Given this list of marker genes CDC16, BUB1B, SPC25, NUP133 (NCBI Gene Id 55746), CENPM, KIF2A, NUP107, CLIP1, ANAPC2, MIS12, ANAPC5, RANGAP1, ZWILCH, SPDL1, DYNC1H1, KIF2B, CENPA, PPP2R5E, PPP1CC, NDE1, SGO1, ERCC6L, ANAPC10, CENPS, PPP2R5D, AHCTF1, UBE2C, CENPH, SEC13, NUDC, KNTC1, ANAPC4, CENPU, ANAPC15, NDEL1, RPS27, ZWINT, PPP2CB, ZW10, DYNC1I2, KIF2C, CENPN, SKA1, SGO2, KNL1, PPP2R5B, SEH1L, DYNC1LI2, UBE2S, KIF18A, NUF2, BUB3, UBE2D1, ITGB3BP (NCBI Gene Id 23421, integrin subunit beta 3 binding protein), CDC26, CENPT, RCC2, NUP37, RANBP2, TAOK1, XPO1, CLASP1, PPP2R1B, ANAPC16, CDC23, NSL1, ANAPC1, DYNC1I1, CKAP5, PPP2R5C, NUP160, ANAPC7, PPP2CA (protein phosphatase 2 catalytic subunit alpha), CENPQ, CENPK, ANAPC11, PAFAH1B1, NUP43, PMF1, CENPF, NUP85, CENPE, B9D2, CLASP2, MAPRE1, MAD2L1, DYNLL2, PLK1, MAD1L1 (NCBI Gene Id 8379), DSN1, NUP98, NDC80, PPP2R1A, CENPP, PPP2R5A, CENPC, CDC20, CDC27, CENPL, CDCA8, BIRC5, DYNLL1, INCENP, SKA2, UBE2E1, CENPO, DYNC1LI1, CENPI (centromere protein I), AURKB, SPC24, BUB1, here is a description of the gene set: species: Homo sapiens part of: Cell Cycle Checkpoints The mitotic checkpoint or spindle assembly checkpoint is an evolutionarily conserved mechanism that ensures that cells with misaligned chromosomes do not exit mitosis and divide to form aneuploid cells. As chromosome attachment to the spindle microtubules is a stochastic process, not all chromosomes achieve alignment at the spindle equator at the same time. It is therefore essential that even a single unaligned chromosome can prevent the onset of anaphase. The ability of the checkpoint to monitor the status of chromosome alignment is achieved by assigning checkpoint proteins to the kinetochore, a macromolecular complex that resides at centromeres of chromosomes that establishes connections with spindle microtubules. <P>The checkpoint proteins monitor, in an unknown way, the mechanical activities between kinetochore-associated proteins and microtubules. Defects in mechanical activities at kinetochores activate the resident checkpoint proteins to initiate a signal that is amplified throughout the cell that ultimately prevents the activation of the proteolytic process that is required for sister chromatid separation and the onset of anaphase. Kinetochores of unaligned chromosomes differ from those of aligned chromosomes in two ways. Kinetochores of aligned chromosomes are saturated with between 20 to 30 microtubules. In addition, poleward directed forces exerted at each sister kinetochore generates tension between them. Unaligned kinetochores on the other hand, are not saturated with microtubules and are not under tension. The mitotic checkpoint detects the presence of unattached kinetochores rather than monitoring for the presence of attached kinetochores. Consequently, unattached kinetochores emit an inhibitory signal that inhibits the biochemical events that are required to initiate the onset of anaphase. The mechanism by which this inhibitory signal is generated at unattached kinetochores has not precisely been determined but the signal is generated as a result of the lack of microtubule occupancy and kinetochore tension. A single unattached kinetochore is capable of preventing cells from exiting mitosis. The mitotic checkpoint provides a way for a localized defect to affect the global biochemical status of the cell. In principle, the signal that is generated at an unattached kinetochore diffuses throughout the cell to affect its target. There are currently two models for how this is achieved. One model is based on the observation that the Mad2 checkpoint protein binds and is rapidly released from unattached kinetochores. The kinetochore is believed to act as a catalyst that converts Mad2 into an inhibitory state that diffuses throughout the cell upon its release from the kinetochore. A second model proposes that the signal is amplified by a kinase cascade much like a conventional signal transduction pathway. This kinase cascade is believed to be comprised of the checkpoint kinases, hBUBR1, hBUB1, hMPS1. Reactome Pathway: Mitotic Spindle Checkpoint